The following is a description of a gene set: species: Homo sapiens Small earlobe Human Gene Set: HP_SMALL_EARLOBE Reduced volume of the earlobe., and this is the list of marker genes: PTPRF, SEC24C, SCARF2, RNU4-2, SMAD4, POLR3A, AHDC1, KCTD1, SLC35C1, FIG4, HNRNPH1, ZMYM2, COMT, HIRA, RBM10, ARVCF, EBF3, SMS, KAT6A, RREB1 (NCBI Gene Id 6239), CDC6, TBX1, COL2A1, GP1BB, JMJD1C, FN1, ABHD5, UFD1